The following is a description of a gene set: Mouse Gene Set: GOCC_AP_3_ADAPTOR_COMPLEX species: Mus musculus A heterotetrameric AP-type membrane coat adaptor complex that consists of beta3, delta, mu3 and sigma3 subunits and is found associated with endosomal membranes. AP-3 does not appear to associate with clathrin in all organisms. In at least humans, the AP-3 complex can be heterogeneric due to the existence of multiple subunit isoforms encoded by different genes (beta3A and beta3B, mu3A and mu3B, and sigma3A and sigma3B)., and this is the list of marker genes: Vps18, Vps33a, Vps11, Vps39, Ap3m2, Ap3b1, Ap3s1, Ap3m1, Vps41, Vps16, Ap3b2, Ap3d1, Ap3s2